Given this list of marker genes INTS10, MAML2, KLHL42, FCGRT, GPS1, SERTAD4, DENND3, CNBP, FBXL12, PIK3IP1, DAPP1, TPP2, HNRNPA1, S1PR1, LIN7C, CCDC174, MARCKS, TRIM59, PLEKHO1, ALKBH4, ACP3, ZNF708, TAFAZZIN, IL16, KCNA3, RBBP5, NUDCD1, DMAC1, SP3, NMBR, MRPL1, SOCS3, TFDP2, ANKRD37, DNAAF10, HNRNPU, ZNF394, DPP6, CD248, CXCR6, ASPA, ATPAF2 (NCBI Gene Id 91647), KCTD5, DELE1, ZNF354C, HBP1 (HMG-box transcription factor 1), DCTN5, AKTIP, TM4SF20, TIFA, RAB8B, GOLPH3L, ADSL, KIF24, FAM118B, ECHS1, RBM45, CTSV, CDK20, ERRFI1, SLX4IP, HMGB2, AKAP8, TEC, RNF128, CCR7, TXNIP, LFNG, ORMDL1, OAS1, TMEM106B, DPY30, BZW2, NUDT7, RAG2, THOC2, WASHC4, NAA40, PEF1, UPF2, UBR3, NAP1L4, SLC35B4, ZFX, RNF146, DNAJC28 (DnaJ heat shock protein family (Hsp40) member C28), SLC25A31, NSUN6, EEF1G, JPT1 (NCBI Gene Id 51155), CELF1, SPACA9, YES1, ATP5MC2, PDRG1, ZNF8, CPLANE2, FBXO46, AP1G2, NFYB, PTCRA, C1orf43, PAN3, TSEN34, TMEM43, UBA6, RDH14, EXOSC4 (exosome component 4), MYLIP, SNAP23, SLC16A1, KLRD1, TTC4, SLFN12L, THAP11, NFKBIA, USF1, MAN1A2, SNRPD3, PCDH17, CDK19, H2BC13, TMED7, C16orf54, RAG1, RAPGEF3, PRCC (proline rich mitotic checkpoint control factor), COLGALT2, TERF2IP, SLAMF6 (SLAM family member 6), PLEKHF1, VPS26A, NCF4, DLAT, CDKN1B, YPEL5, OXA1L, TRMT5, PDCD2 (programmed cell death 2), DNAJC7, SDC2, NSL1, PRXL2B, RAD52, ZNF280D, THAP7, SLFN12, NHSL1, CRLS1, IL7R, ARSJ, MS4A6A, TMEM186, CAB39 (NCBI Gene Id 51719), YME1L1, EIF3E, RNF181, CD164, IK, CHCHD10, PHOSPHO2, C1QL3, HMGCL, DHDDS, ARRDC3, GPR176, KPNA3, MGME1, CAP1, CYP2D6 (cytochrome P450 family 2 subfamily D member 6), TP53INP1, SKA2, GPI, GALK2, TRIQK (triple QxxK/R motif containing), FGFR1OP2, WRAP73, SMPD4, JAGN1, IER5, PDIA4 (NCBI Gene Id 9601), KATNB1, CSPG5, ETFDH, ZFAND6, THYN1, OTULINL, SLC29A3, DDIT4, MOB2, CLASP2, IL1RL1, OTUB1, CASP2, ANAPC16, ZBTB3, ZC3HAV1, PLEKHN1, SOD2, ASH2L, here is a description of the gene set: Genes up-regulated in B cells: dark zone versus naïve. from publication Victora GD, Schwickert TA, Fooksman DR, Kamphorst AO, Meyer-Hermann M, Dustin ML, Nussenzweig MC (PMID 21074050) Microarrays of gene expression in mouse germinal center B cells photoactivated in the light zone or dark zone, and of naïve cells for comparison. We used microarray data to identify genes differentially expressed by B cells in the light and dark zones of the germinal center. Human Gene Set: GSE23925_DARK_ZONE_VS_NAIVE_BCELL_UP studied in species Homo sapiens